Given this list of marker genes CASP7, DAPK1, ATM, MAPK8IP1, BCL2L1, TNFRSF10B, EYA2, SGPP1, EGLN3, TNFRSF21, here is a description of the gene set: Human Gene Set: RAMJAUN_APOPTOSIS_BY_TGFB1_VIA_SMAD4_DN from publication Ramjaun AR, Tomlinson S, Eddaoudi A, Downward J (PMID 16909112) Apoptotic genes dependent on SMAD4 and down-regulated in AML12 cells (hepatocytes) after stimulation with TGFB1. studied in species Mus musculus Transforming growth factor-beta (TGFbeta)-activated signalling pathways can lead to apoptosis, growth arrest or promotion of malignant behaviour, dependent on cellular context. The molecular mechanisms involved in TGFbeta-induced apoptosis remain controversial; although changes in gene expression are thought to be pivotal to the process, several different candidate apoptotic initiators and mediators have been proposed. Smad4, a critical component of the TGFbeta-induced transcriptional machinery, is shown here to be essential for induction of apoptosis. Gene expression analysis identified the proapoptotic Bcl-2 family members, Bmf and Bim, as induced by TGFbeta, dependent on both Smad4 and p38 function and the generation of reactive oxygen species. TGFbeta-induced Bmf and Bim localize to cellular membranes implicated in apoptosis. Inhibition of the TGFbeta-induced expression of both these proteins together provides significant protection of cells from apoptosis. The TGFbeta-triggered cell death programme thus involves induction of multiple BH3-only proteins during the induction of apoptosis.